The following is a description of a gene set: species: Homo sapiens Reactome Pathway: Defective amino acid transport by SLC7A7 causes lysinuric protein intolerance (LPI) part of: SLC transporter disorders SLC7A7 encodes the y+L amino acid transporter 1 (y+LAT1). As a heterodimer with SLC3A2 in the plasma membrane, SLC7A7 mediates the exchange of arginine (L-Arg) for leucine (L-Leu) and a sodium ion (Na+). The physiological concentrations of arginine and leucine are expected to favor arginine export (Schweikhard & Ziegler 2012). Defects in SLC7A7 can cause Lysinuric protein intolerance (LPI; MIM:222700), a metabolic disorder characterised by decreased cationic amino acid (CAA) transport at the basolateral membrane of epithelial cells in the intestine and kidney, increased renal excretion of CAA and orotic aciduria. There is extreme variability clinically but typical symptoms include refusal to feed, vomiting and consequent failure to thrive. Hepatosplenomegaly, hematological anomalies and neurological involvement are recurrent clinical features.<br>, and this is the list of marker genes: SLC3A2, SLC7A7